Given this list of marker genes TCF7L2, HIF1A (NCBI Gene Id 3091), VGLL4, CTBP1, FOXO3, NR5A1, SMAD3, PPARD, ATF7, STK36, CTBP2, NFKB1, HDAC6, ZBTB17, BAIAP2, ZBTB8A, PER2, HAND2, PHF12, ESR1, ENO1, HNF1B, HDAC1, RORA, LCOR (NCBI Gene Id 93376), HES1, TP53, PAX6, FLYWCH1, FAM89B (family with sequence similarity 89 member B), ETS1, NR1H4, CDK9, PER3, EHMT2, PPARA, WIZ, SUZ12, MAP3K7, RARA (retinoic acid receptor alpha), LMO2, LEF1, CIT, CNOT2, AR, TRERF1, NR5A2, SREBF1, CREBBP, SIX1, LHX3, UBE2I, MTF2, HDGF, NR4A3, SP1, HDAC5, RUNX1, PBX1 (NCBI Gene Id 5087), ZNF618, NHLH2, EPAS1, TWIST1, ZNF644, MED1, GATA6, CHD4, ZBTB49, RXRA, FOS, NFE2L2, TFAM, TEAD2 (NCBI Gene Id 95515), CTNNB1, EZH2, THAP7, PHF1 (PHD finger protein 1), HDAC2, TRAPPC2B, STAT1, CTCF, CREB3, STAT6, USP11, ELOC, RUNX3, RELA, EED, CTNNBIP1, PGR, SMAD4, EHMT1, SMARCD3, NR1D1, MED6, ELOB, RFX5, KLF4, SMARCA4, SIX3, TERT, PPARG, GATA1 (NCBI Gene Id 2623), THRB, PER1, EP300, CCNT2, BEX1, HDAC3, ZBTB16 (NCBI Gene Id 8070), CBX3 (chromobox 3), BCL6, RPL23, JUND, MED25, CHD6, GATA3, HAND1, FOXP2, CREB1, TP73, HMGA1, NEK6, AHR, ZBTB7A, GATA2, MYC, here is a description of the gene set: Binding to a transcription coregulator, a protein involved in regulation of transcription via protein-protein interactions with transcription factors and other transcription regulatory proteins. Cofactors do not bind DNA directly, but rather mediate protein-protein interactions between regulatory transcription factors and the basal transcription machinery. studied in species Homo sapiens Human Gene Set: GOMF_TRANSCRIPTION_COREGULATOR_BINDING